The following is a description of a gene set: species: Homo sapiens Human Gene Set: GOMF_BETA_2_MICROGLOBULIN_BINDING Binding to beta-2-microglobulin., and this is the list of marker genes: FCGRT, HLA-F, MICA, MR1, HFE, HLA-E, CD1D, HLA-A, HLA-H